The following is a description of a gene set: The chemical reactions and pathways involving xylulose 5-phosphate, a derivative of the ketopentose xylulose phosphorylated at the 5 carbon; it is an intermediate in the pentose phosphate pathway. Mouse Gene Set: GOBP_XYLULOSE_5_PHOSPHATE_METABOLIC_PROCESS studied in species Mus musculus, and this is the list of marker genes: Akr1a1, Cryl1, Xylb, Sord, Dcxr, Tkt